Given this list of marker genes CCL3, MIR142, MIR128-1, MMP8, CTSC, TREM2, TTBK1, LRRK2 (leucine rich repeat kinase 2), TAFA3, STAP1, here is a description of the gene set: species: Homo sapiens Human Gene Set: GOBP_POSITIVE_REGULATION_OF_MICROGLIAL_CELL_ACTIVATION Any process that activates or increases the frequency, rate or extent of microglial cell activation.